The following is a description of a gene set: Human Gene Set: HP_KYPHOSIS Exaggerated anterior convexity of the thoracic vertebral column. studied in species Homo sapiens Kyphosis, and this is the list of marker genes: NPR2, MBTPS1, PUS1, EBP, MGAT2, WDR45B, TMEM165, SBF2, GBA2, PTCH1, KMT2C (NCBI Gene Id 80260), RAB18, KANSL1, GTF2E2, CLP1, DNA2, AIP, LMNA, HACE1, TRPV4, ABCC6, TMEM270, CLCF1, PPIB, SCAF4, ASCC3, SNX14 (sorting nexin 14), MEIS2, ACTB, PTDSS1, HSPG2, LAMA2, VPS35L, SHROOM4, GJB1, NAA10 (N-alpha-acetyltransferase 10, NatA catalytic subunit), TGFB1, ZMYM3, SYT2, ACTA1, FKBP6, SLC1A2, VPS37A, COMP, ZMPSTE24, SETBP1, DMD, HMBS, RERE, RNU12, DHCR7, ZC4H2, MMP14, LHX3, PWAR1, FLVCR1, COL6A1, XYLT2, NDRG1, SRCAP, NKX3-2, TAF4, CHST3, MBTPS2, SRD5A3, TFAP2A, BIN1, GBA1, SOX9, PPP1R15B, HECTD4, RNF113A, BAZ1B, FOXC2, PIGG, CASZ1, CCDC8, ATP7A (ATPase copper transporting alpha), RPS6KA3, FILIP1, SEC23B, NELFA, RAB3GAP1, DYM, ARID1B, NSDHL, ERCC2, GALNS (NCBI Gene Id 2588), MED25, SLC52A3, NOTCH2, SNAP25, RBM28, BCOR, HRAS, SPART, CHD8, RTL1, FKTN, COL13A1, ERCC1, FLNA, SEC24D, NEPRO, PEX7, RYR1, SH3PXD2B, MFN2, ACBD6, SMC1A, CTDP1, EGR2, WIPI2, TBX2, CCND1, GDAP1, NSD1, ATAD1, TTC5, SNORD115-1 (NCBI Gene Id 338433), FBN1, MYO1H, NEB, TCF12, FLNB, POLD1, CUL4B, ERCC8, HTRA1, SLC39A13, ATP6V1B2, TONSL, INPP5K, ATP6V1A, UFSP2, ROBO3, ITGA7, MGME1, SLC10A7, CFL2, FKBP14, HDAC4, GLE1, LGI3, PNKP, GLS, SIN3A, NDUFS3, PRKG2, SLC18A3, LMOD3, ACP5, YARS2, PIEZO2, DSE, SPARC, HS2ST1, ATRX, ATP6V0A2, GRIA3, PLOD2, SKI, SMAD4, FBN2, DVL1, TARS1, DLK1, ATG7, NPAP1, MEG3, SURF1, TTI2, USP8, ELN, RFC2, SPG11, UBE4B, TLK2, EMD, FA2H, FHL1, TBC1D20 (TBC1 domain family member 20), TPM2, CSF1R, AIMP1, PLOD1, EIF4H, DICER1, NEMF, MESD, MAP3K20, DYRK1A, CRELD1, MAPK8IP3, EHMT1, AIMP2, STAC3, LUZP1, PRKAR1A, ITPR1, TPI1, COL1A2, GTF2I, CTBP1, DNAJC30, PDPN, VAMP1, ATP6V1E1, NCF1, ARID2, CRPPA, SLC16A2, SLC26A2, NEU1, TBX5, JPH1, VPS37D, MVK, SMARCAL1, ERCC3, ANKRD11, SLITRK2, SVIL, GPR101, DCC, CLIP2, GTF2IRD1, MPZ (NCBI Gene Id 4359), HGSNAT, FGFRL1, USP7, WNT1, TRAPPC2, RAB3GAP2, COL6A3 (NCBI Gene Id 1293), KCNA1, CPLX1, WDR81, DSTYK, IKBKG, SNRPB, MESP2, BRAF, GZF1, B3GALT6, PIK3C2A, CUL7, LFNG, NRAS, MAGEL2, MMP2, HES7 (hes family bHLH transcription factor 7), POMT1, MCM3AP, JAG1, PRPS1, ALDH3A2, PLAAT3, VPS13B, UBA1 (NCBI Gene Id 8247), PHF6, COL1A1, HGD, MRPS34, LIMK1, RECQL4, IDS, PRDM16, KLC2, LETM1, TELO2, PIK3R2, TMEM43 (transmembrane protein 43), KLLN, ALG1, TRMT10A, SON, IDUA, HERC2, NTNG1, APC2, UPF3B, SNORD116-1 (small nucleolar RNA, C/D box 116-1), PIK3CA (NCBI Gene Id 5290), CTSK, ZNF407, UBAP2L (NCBI Gene Id 9898), MECP2, BUD23, ARSL, SYNE1, FIG4, AIFM1, SDHC, GNAS, RMRP, TPM3, IPO8, SLC5A7, ROR2, GORAB, CRLF1, FARS2 (phenylalanyl-tRNA synthetase 2, mitochondrial), MEGF8, KIF22, GABRD, FUT8, ARSB, METTL27, SMC5, PAPSS2 (3'-phosphoadenosine 5'-phosphosulfate synthase 2), L1CAM, MKRN3, PRX, SCN4A, WASHC5, CYP27A1, HLA-B, MAN2B1, PI4KA, GNPTAB, RIPPLY2, P3H1, PTPN11, POLR3A, MAPT (NCBI Gene Id 8152), PWRN1, KLHL41, HTT, COG1, GTF2IRD2, SDHD (NCBI Gene Id 91899), PMP22, ALG9, CRTAP, EXTL3, ZBTB20, GUSB, DKK1, LRP5, KCNN3, SETD5, EZH2, MYL2, PRDM13 (NCBI Gene Id 59336), KMT2E, WNT3A, FOXG1, KRAS, TUBB4A, P4HTM, TMEM147 (NCBI Gene Id 84721), CARS1, SPTBN1, NSD2, BMP4, TUBB3, NONO, SPRED2, SIL1, TNFRSF11B, RUNX2, COL2A1, DLL3, ASXL2, NDUFAF4, AEBP1, PPP1R12A, CHRNG, PMM2, RAB23, SPEN, SYNE2, NFIX, TNNT1, USF3 (upstream transcription factor family member 3), COPB1, NDUFAF1, GTF2H5, H4C9, CCDC22, HACD1, UBTF, SELENON, ALMS1, PRKCZ, ERCC6, VPS33A, PHF8, AGA, COL12A1, OCRL, NARS1, ABL1, BICD2, BGN, PLAA, CHST14, AP1G1, CDKL5, PTEN, B4GALT7, ADAMTS15, AUTS2, AKT1, CBS, HERC1, OBSL1, LBR, NUP88, CLIC2, SMS, PDE11A, AGRN, FUCA1 (alpha-L-fucosidase 1), BMP1, SLC52A2, MPLKIP, MYH3, FGFR3, TGFB3, SH2B1, CCDC32, NF1, DVL3, WDR11 (NCBI Gene Id 79207), TCTN3, TBL2, MAP2K1, FKRP, KCNAB2, MYO9A, TAF1, GNPTG, CANT1, GABBR2, MTTP, CTCF, CDH11, STX1A, ERLIN2, HMGB3 (NCBI Gene Id 3149), CCN6, CHAT, NOTCH3, AARS1, SDHB, COL6A2, MMP23B, SLC25A1, TRIO, GLB1, FBXO28, KY, MADD, P4HB, DPYSL5, FKBP10, RSPRY1, AMER1, H1-4, NUP107, ALDH18A1, GTPBP2, MLXIPL, MED12L, NXN, DNMT3A, TOR1A, RET, POP1, PUF60